Given this list of marker genes Kansl1, Phf20l1, Ing3, Mrgbp, Yeats2, Phf20, Epc2, Yeats4, Msl3l2, Vps72, Actbl2, Msl1, Dmap1, Msl2, Wdr5, Morf4l1, Msl3, Ogt, Ep400, Kansl2, Brd8, Actl6a, Actl6b, Actb, Actg1, Ruvbl2, Ruvbl1, Epc1, Brd8dc, Hcfc1, Atf2, Mcrs1, Trrap, Acte1, Kansl3, Meaf6, Morf4l2, Mbtd1, Kansl1l, Kat5, Kat8, here is a description of the gene set: A protein complex which is capable of H4 histone acetyltransferase activity. species: Mus musculus Mouse Gene Set: GOCC_H4_HISTONE_ACETYLTRANSFERASE_COMPLEX